Given this list of marker genes Tjp1, Stard10, Abcb1a, Mmp13, Abcb1b, Abcc2, Mtdh (metadherin), Abcb4, Dpp4, Abcb11 (ATP-binding cassette, sub-family B member 11), here is a description of the gene set: species: Mus musculus Mouse Gene Set: GOCC_INTERCELLULAR_CANALICULUS An extremely narrow tubular channel located between adjacent cells. An instance of this is the secretory canaliculi occurring between adjacent parietal cells in the gastric mucosa of vertebrates.